The following is a description of a gene set: studied in species Homo sapiens Any process that activates or increases the frequency, rate or extent of the chemical reactions and pathways resulting in the breakdown of substances. Human Gene Set: GOBP_POSITIVE_REGULATION_OF_CATABOLIC_PROCESS, and this is the list of marker genes: PAN2, MIR192, RNF128, DET1, YTHDF2, IER3, FBXO7, UBXN2A, APP, GTPBP1, AGO1, RNF152, PSMC1, NFE2L2 (NFE2 like bZIP transcription factor 2), DCPS, STUB1, MIR20A, HSPB8, RAB3GAP2, MIR24-1, SH3RF2, TGFB1I1, SGTA, HK2, TMEM259, UVRAG, ATXN3L, ELOB, ALKBH5, CNOT7, MIR140, PRKD1, ULK1 (NCBI Gene Id 8408), MIR608, MIR424 (microRNA 424), WNT5A, SH3RF1, HECTD1, MIR708, PRKCE, TRIM67, FMR1, PAN3, XBP1, VSIR, RHBDD1, NOCT, MIR373, CEBPA, TWIST1, NUPR1, TRIB1, GIT1, TBK1, TOB1, CHFR, SNX1, ZNF268, RCHY1, IRGQ, UFL1, KCNE2, CPT1A, MIR27B, SCT, PSEN1, MIR130A, CSNK2A3, DTX3L, IFNG, MIR495, PABPN1L, DIS3L2, MIR663A, RNF31, DNAJB2, MTOR, IRS2, METTL14, ADORA1, PHKA1, FURIN, CLU, FZR1, SNX30, MIR23A, LDLR, HAMP, DAB2IP, QKI, CLSTN3, BAG2 (BAG cochaperone 2), HMOX1, RBM24, PLEKHN1, SOCS5, DAB2, SH3BP4, KAT2B, RACK1, DISC1, MIRLET7E, NRDC, LRRK2, ATG5 (autophagy related 5), VPS35, CSDE1, AGO4, GRSF1, MAP2K1, TRIB3, ZDHHC19, MIR365A, MIR342, ORMDL3, MIR544A, MIR130B (microRNA 130b), FXR2, SOX17, MIR19B1, MIR497, AKT2, ELAPOR1, PACSIN3, FOXO3, HTR2A, TNRC6A, MIR214, NOP53, MIR151A, FBXW8, PDE12, MUL1, PIK3CB, NEDD4L (NCBI Gene Id 93998), MSN, MIR885, CSNK1D, DXO, ZSWIM8, PIWIL1, VIP (vasoactive intestinal peptide), MIR135B, ANGPTL3, CSNK2A1, LAPTM5, MIR200B, GATA5, PLEKHF1, RFPL1, RNF180, NEAT1, POLR2G, DACT1, IKBKG, TMTC3, MDM2, C4BPB, BECN1, MAPK3, FYCO1, PRICKLE1, TSC2, RNF139, LRP2, MEX3D (mex-3 RNA binding family member D), EZR, MIR106B, MARCHF2, MIR181A2, MIR211, RNFT1, BNIP3, HTT, P2RX7, GSK3B, TRIB2, SETD2, CREBRF, CCNY, MIR501, BAG6, PINK1, PNLDC1 (PARN like ribonuclease domain containing exonuclease 1), NANOS1, MIR210, MIR483, ZBTB20, MIR142, MIR34B, GTSF1, TFEB, YBX1, FAF1, SMURF1, HSPA1A, PARN (NCBI Gene Id 5073), APOE, NPRL3, AMER1, RILP, TNKS1BP1, MIR302A, ECSCR, SNX18, GPD1, DEPTOR, PUM1, HMGB1, OAZ1, MIR199B (NCBI Gene Id 406978), MIR485, MIRLET7A1, GGA3, MIR18A, PCSK9, UBQLN2, PSMC2, BAX, IL6, MIRLET7B, VPS11, TRIM32, PLIN5, CDK5RAP3, OPTN, BNIP3L, PSMC3, GSK3A, AGTPBP1, XIST (NCBI Gene Id 7503), FXR1, SH3RF3, TNFAIP3, ATG7, ZC3HAV1, SPTLC2, HNRNPU, PSMC6, MIR19A, VCP, MIR520C, RB1CC1, TOMM7, MIR326, SH3D19, CDC37, UPF1, SUPV3L1, CCDC22, KDR, YTHDF3, DAPK1, WFS1, TRIM8, SNX9, SOX9, HSPBP1, CELF1, BARD1, IGF1, ADAM8, TPCN1, MTLN, MIRLET7C, SUMO2, DHX9, AMBRA1 (autophagy and beclin 1 regulator 1), DCP1A, MIR98, PAQR3, PSMC5, CDC20, PIK3C2A, ADCY10, NOD2, VPS28, KEAP1 (kelch like ECH associated protein 1), TNFRSF1B, USP20, MIR103B1, TF, MIR9-1, STX5, NT5C3B, RDX (NCBI Gene Id 5962), MIR517C, EGLN2, SMAD7, TUT7, SESN3, WDR45, SMCR8, PSMC4, MIR137, TIPARP, GPC3, CERS1 (ceramide synthase 1), PRKAA1, MEFV, CNOT1, ENDOG, CNOT6L, CDK16 (NCBI Gene Id 5127), RAD23A, PPP2R3A, MIR195, ROCK2, MIR93, SPTLC1, C4BPA, USP5, GAPDHS, TNRC6C, FUT1, DTL, YTHDF1, METTL16, PNPLA2, HSPA1B, FLCN, PATL2, MYLIP, MIR655, KLHL40, HNRNPD, CNOT3, PPARA, ZYG11B, ACTN3, ABHD5, HSF1, KAT5, NEDD4 (NEDD4 E3 ubiquitin protein ligase), GGA1, IL4, CBFA2T3, TMEM59, FOXO1, MIR519D, RALB, USP13, AXIN1, TENT4A, MIR149, ATG16L1, PRKCD, VPS13D, MIR26B, PHKG2, ARNT, MIR145, PABIR1, CAMKK2, SUPT5H, SLC25A4, SIRT6, PARK7, ZC3H12A, ASB11, LPCAT1, C9orf72, HIF1A, MIR223, AGO3, AADAC, PLK2, TNRC6B, CSNK1E, CNOT8, NSF (N-ethylmaleimide sensitive factor, vesicle fusing ATPase), IRS1, PNPT1 (polyribonucleotide nucleotidyltransferase 1), PTK2, TLR9, PATL1, MIR1-1, TP53INP1, TAF1, PIM2, DVL1, TUT4, KHSRP, MOV10, PLK1, AXIN2, LIN28B, MIR204, DAGLB, LACRT, MLH1, SYNCRIP, LRP1 (NCBI Gene Id 4035), RPGR, MIR517A, MIR190B, PIP4K2B, ZFP36, MIR302C, CALCOCO2, MIR625, MIR30B, UBE2A, ASB5, GPLD1, MIR564, GNAI3, SAMD4A, DDRGK1, PLK3, UBQLN1, RPTOR, TICAM1, ABCD2, NUB1, APOA2, FTO, GPSM1, NPRL2, CNOT6, CNOT9, MIR100 (microRNA 100), PIAS1, GABARAP, ATXN3, ATF6, APC (NCBI Gene Id 324), WIPI1, HERPUD1, EPM2A, INS, RHBDD3, DNM3OS, MIR29B1, BCAP31, SRC, NDUFA13, NEURL3, RIDA, TNF, HSP90AA1, IFNB1, OSBPL7, MALAT1, SUMO1, MAP3K7, SNX33, SH3GLB1, MAPK9, MIR146A, GCLC, ATG101, SNF8, ROCK1, LSM1, SEC22B, ZFP36L2, MIR20B, ABCA2, SQSTM1, ELAVL1, CAPRIN1, MIR125A, TRIM23, IDE, MIR181D, OAZ2, NOD1, OAZ3, MIR491, SCOC, PRKN, DCAF1, MIR665, DELE1, MIR486-1, MIR423, SLC25A5, METTL3, SORL1, ATP5IF1, IL33, UCHL1, CUL4B, MIR543, IRGM, MIR27A, PTEN (NCBI Gene Id 8037), TENT4B, HUWE1, MLXIPL, DHX36, MIR519A1 (microRNA 519a-1), SLC4A4, RC3H2, UBR3, CBLB, MOAP1, ASB9, MIR185, SESN2, VDAC1, EGF, PTPN1, MIR4286, MIR203A, SNX4, MIR133A1, TMX1, CNOT2, MIR128-1, BAG3, GBA1, APOA4, L3MBTL3, TRIM21, TRIM13, MIR206, NANOS3, PIP4K2A, DEPDC5, SIRT1, RC3H1, SAMD4B, DHRSX, ZC3H18, MIR106A, RUFY4, ENPP7, CDC20B, PYHIN1, DCN (decorin), EIF2AK1, DND1, IL1B, RGMA, MIR125B1, RAB7A, RIPK2, BAD, SNCA, NDFIP1, NKD2, AGBL4, WAC, ATG2A, EIF4ENIF1, MIR212, LARP1, TARDBP, PRXL2C, ZFAND2A, MIR181B1, CNOT10, TRIM65, CNOT4, HOTTIP, MIR320A, MID2, AGO2, SGSM3, ADRA2A, BTG2, PIWIL2, PRR5L, TRIM71, RAB37, TRAF7, AURKA, MTDH, MIR329-1, LRSAM1, SESN1, DAOA, RAB3GAP1, STING1, APOA5, TTC5, DDB1, CAV1, CAV3, CUL4A, FBXW7, PIP4K2C, NANOS2, PSMD10, SIRT2, CPEB3, TRIM22, RBX1, STK11, PAIP1, SLC35D3, AKT1, MLST8, CD81, MIR337, PAFAH1B2, ADRB2, FBXL5, UBR4, DCP2, VGLL4, PUM2, ZFP36L1, RNF41, SOCS4, PABPC1, WDR24, NKD1, SNX7, MIR200C, ZC3H12D, FBXO22, NNT, RNF185, ZER1, TREM2, SVIP, ADAM9, ATG13, IGF2BP1, CDKN1B, APOC2, CNOT11, INSR, CSNK1A1, GIGYF2, TNFSF12, ABCD1, BBS7, MIR191, COP1, MIR340, PRKAA2, PTK2B, DIS3, MIR193A, DDA1, RNFT2, ITCH, MIR562, DCP1B, HDAC6, MIR181C, MIR96, TOM1